Given this list of marker genes PAQR8, HCK (HCK proto-oncogene, Src family tyrosine kinase), IFNGR1, CLCF1, DLL1, CEMIP2, PPP2R5E, RALB, DOP1B, CNST, SUN2, NTRK3, MIDEAS, PTK2, DOCK11, PTBP3, SYNPO, RPL13AP5, FRMD4B, ZDHHC2, LRPPRC, TFEB, TNFRSF10B, NUDCD3, CYB561A3, CELF2, ZNF678, RPL13AP20, PLCG2, ACTB, CAMK2N1, HDHD3, NEXN, CCDC93, BTF3L4, KHDRBS2, TANGO6 (NCBI Gene Id 79613), PFDN5, TNFAIP8, KPNA5, ZC3H6, TMEM260, ADD3, ZNF789, ZFHX3 (zinc finger homeobox 3), FIG4, ZFP14, STX7, STK10, SORD, KIF5C, ALPK1, ARHGAP25, RALGPS2, MIR600HG, ADAP2, EBI3, PAPOLG, RAB11A, FCRLA, ELF4, ZNF610, ZNF850, AIDA, AHDC1, TNIP2, CRBN (NCBI Gene Id 51185), IQCG, DLEU1, LIPE, KLHL36, BTG1, RABEP1, DOCK2, L3MBTL3, COLGALT1, CHD4, ATP2B1, STAT5A, CD1D, SMC6, NAPEPLD, PTPN6, NR4A1, PIK3IP1, LPIN2, CD1C, ABCA15P, GIT2, RAD51B, ZSCAN18, ABHD6, SPOCK2, PROX1, SMAD3, FLNB, KAT2A, AKAP11, MYCBP2, PDK3, CDC42BPB, HNRNPH3, RNASEH2B, GSAP, SMIM14, TERF2, LTB, WDR17, ZC3HAV1, PTGS1, ST3GAL3, MEF2A, LTA, XAF1, APAF1, SPG11, MAP4K5, MIDN, DDX39B, FMNL3, NRIP3 (nuclear receptor interacting protein 3), NUDT3, MX2, ZBTB10, CDK5R1, JAM3, SIN3A, SIDT2, MANBA, PCSK7, TMED8, PYGM, PTPRCAP, NEK6, PHF20 (PHD finger protein 20), ARHGEF2, HERC4, HDAC9, LAT2, PHKA2, KRBOX4, CD79B, ANK3, FCMR, OR52N4, BCAS1, TASOR, IFIT3, HIP1R, SLC2A14, PCYOX1L, POU6F1, SPECC1L, TGOLN2, RNASET2, ETS1, UBAC2, RNF130, SNORA48 (NCBI Gene Id 652965), WASHC4, SCRN1, TSPAN32, RUBCNL, EPB41L5, CEP126, TBC1D5, ELP3, THADA, MED15, CNPY3, JAK3, SSH2, DENND11, CAMK1D (NCBI Gene Id 57118), RUFY1, TOP1MT (NCBI Gene Id 116447), DMD, IFNGR2 (NCBI Gene Id 3460), CHD7, RNF20, SLC25A37, CR2, STXBP3, ASB13, PPM1K, CDC40, BICDL1, FBXW11, UTRN, LYST, PSIP1, MRPS25, MYO9A, JUNB, SERPINB7, PHF14, here is a description of the gene set: species: Homo sapiens Human Gene Set: GSE20727_CTRL_VS_H2O2_TREATED_DC_DN Genes down-regulated in dendritic cells: untreated versus hydrogen peroxide. from publication Miyazawa M, Takashima A (PMID 22974541) Identification of ROS induced genes on dendritic cells Dendritic cells were incubated for 15 min with or without a ROS inhibitor (DPI), washed extensively and incubated for 30 min with a chemical allergen (DNFB), hydrogen peroxide, and vehicle alone in HBSS containing DPI or vehicle. After washed extensively, the samples were post-incubated for 5.5 h with DNFB, hydrogen peroxide, or vehicle in complete culture medium containing DPI or vehicle.